Given this list of marker genes IGHV1-69, FCGR3A, IGKV3D-20, IGKV1-16, IGLV3-27, IGLV1-47, IGKV5-2, IGLV3-25, IGLV6-57, IGKV2D-30, IGLV2-11, IGHV3-11, IGLV1-51, IGHV2-5, IGHV1-46, FGR, IGHV4-39, IGHV3-13, FCGR2A, IGKV1-33 (immunoglobulin kappa variable 1-33), IGKV1-5, IGLV2-8, SYK, IGLV2-23, IGHV4-59, IGKV2D-40, IGHV3-33, IGLC3, IGKV1D-12, IGHV3-30, IGLV3-19, IGLV2-14 (NCBI Gene Id 28815), IGLV1-40, CD247, IGKV1D-16, IGKV2-28, IGHG4, IGHV3-23, IGKV3-11, IGKV1-17, IGKV1D-39, IGHV3-7, IGHV3-53, SRC, FCGR1A, IGKV3-20, IGHG1, IGLV1-44, IGLV3-21, IGLC2, IGKV2-30, IGHV3-48, YES1, IGKV1-12, IGLV7-43, IGKV1D-33, HCK, IGKV1-39, IGHG2, IGHV2-70, CD3G, IGHV4-34, IGKV2D-28, LYN, FYN, IGLV3-1, IGHV1-2, IGKV3-15, IGKV4-1, here is a description of the gene set: Human Gene Set: REACTOME_FCGR_ACTIVATION species: Homo sapiens FCGR activation